Given this list of marker genes CUBN, LMBRD1, MMACHC, CBLIF, MMUT, CD320, TCN2, MTR, TCN1, MMAB, here is a description of the gene set: studied in species Homo sapiens Human Gene Set: GOMF_COBALAMIN_BINDING Binding to cobalamin (vitamin B12), a water-soluble vitamin characterized by possession of a corrin nucleus containing a cobalt atom.